The following is a description of a gene set: studied in species Homo sapiens Creation of the central hole of a tube in an anatomical structure through which gases and/or liquids flow. Human Gene Set: GOBP_TUBE_FORMATION, and this is the list of marker genes: FUZ, IFT122, LMO4, SHH, FGFR2, HES5, CC2D2A, MTHFD1, SPINT2, MMRN2, OPA1, VASP (NCBI Gene Id 7408), LHX2, DEAF1, TEAD2, FGF10, HAND1, PHACTR4, MIB1, RALA, SIX1, IFT57, BCL10, TCTN1, WDR83, PODXL, IFT52, COBL, FGF8, CEP290, EDAR, FOLR1, KIF20B, BMP7, SFRP1, TGIF1, GLMN, PIK3CD, STIL, TGM2, BBS4, SDCCAG8, SOX9, CASP3, TGFB1, NOTCH1, NUP50, ST14, TRIM71, BMP4, ATOH8, DVL2, TSC1, MIR210, SOX8, WNT6, PFN1, EGF, PTCH1, HOXA1, APAF1, RARG, DLC1, CFL1, GREM1, EDA, NOG (NCBI Gene Id 9241), LIAS, PRKACA, CTNNB1, LUZP1, LRP2, ZEB2, TGFB2, GDNF, NODAL, MTHFR, RET, HS2ST1, PLXNB2, BRD2, TCAP, GRHL2, OVOL2, BCL2L11, WNT4, CELSR1, GATA3, TSC2, YWHAZ, SUFU, MKS1, SCRIB, ARHGAP35, ABL1, WNT9B, NCKAP1, CDK20, SLC39A12 (solute carrier family 39 member 12), WNT5A, TRAF6, HNF1B, SEMA4C, PRICKLE1, FGF2, SALL4, KAT2A, FZD3, SPECC1L, PROX1, SPINT1, OSR1, MED12, PRKACB, GDF7, NFIB, SDC4, FZD6 (frizzled class receptor 6), CLUAP1, CTHRC1, TMED2, IFT172, STK4, CITED2, HESX1, BMP5, PAX8, SKI, TWIST1, IRX2, SFRP2, GRHL3, ADM, SIX4, STK3, CECR2, RPS7, ALX1, ITGB1BP1, PTK7, VEGFA, IRX1, TULP3, MTHFD1L, KDM2B, RARA, IRX3, HIF1A, PAX2, SEC24B, DAB2IP, RGMA, VANGL2